The following is a description of a gene set: Catalysis of the reaction: a triacylglycerol + H2O = a diacylglycerol + a fatty acid + H+. Human Gene Set: GOMF_TRIACYLGLYCEROL_LIPASE_ACTIVITY species: Homo sapiens, and this is the list of marker genes: PNPLA3, GPIHBP1, PLB1, ABHD2, LIPE, PNLIPRP3, PNPLA2, PNPLA5, LPL, APOA5, LIPK, DAGLB, PNLIPRP2, PNPLA1, DAGLA, DDHD2, ABHD5, LIPN, LIPC, PNPLA4, APOH, CEL, APOC2, PNLIPRP1, LIPM, LIPG, AADAC, PNLIP, LIPF